The following is a description of a gene set: studied in species Homo sapiens Human Gene Set: REACTOME_PHOSPHOLIPASE_C_MEDIATED_CASCADE_FGFR1 Phospholipase C-mediated cascade: FGFR1, and this is the list of marker genes: FGF5, FGF3, FGF4, FGF20, KL, FGF23, PLCG1, FGF8, FGF6, FGF9, FGF1, FGF10, FGF17, FGF2, FGFR1, FGF22